The following is a description of a gene set: Semaphorin interactions Mouse Gene Set: REACTOME_SEMAPHORIN_INTERACTIONS species: Mus musculus, and this is the list of marker genes: Pak3, Rhoa, Cdk5r1, Dpysl3, Sema4a, Rras, Trem2, Plxna1, Arhgap35, Tyrobp, Cd72, Gsk3b, Rock2, Nrp1, Rac1, Rhob, Pak1, Plxnb1, Tln1, Fyn, Hsp90aa1, Erbb2, Sema5a, Sema6d, Crmp1, Rhoc, Limk1, Dpysl2 (dihydropyrimidinase-like 2), Arhgef12, Plxnb3, Farp2, Sema7a, Arhgef11, Plxnc1, Hsp90ab1, Sema4d, Sema3e, Plxna2, Dpysl5, Rnd1, Cdk5, Fes, Met (met proto-oncogene), Plxna3, Plxna4, Ptprc, Dpysl4, Pak2, Pip5k1c, Plxnd1, Rock1